Given this list of marker genes CNOT9, PATL1, TNKS1BP1, CNOT7 (CCR4-NOT transcription complex subunit 7), CNOT2, CNOT11, CNOT6, TOB1, ZFP36, CPEB3, CNOT3, CNOT10, CNOT1, CNOT4, CNOT6L, CNOT8, here is a description of the gene set: species: Homo sapiens Human Gene Set: GOCC_CCR4_NOT_COMPLEX The Ccr4-Not complex is an eukaryotically conserved deadenylase that can initiate cytoplasmic mRNA decay, and reduce translation by releasing poly(A)-binding protein (Pab1/PABPC1). Ccr4-Not contains seven core subunits, including two poly(A)-specific exonucleases, Ccr4/CNOT6/CNOT6L and Caf1/Pop2/CNOT7/CNOT8.